Given this list of marker genes CLCN2, CLCN3, CLCNKA, ANO6, CLCN4, TMC4 (NCBI Gene Id 147798), CLCNKB (chloride voltage-gated channel Kb), CLCN1, CLCN6, ANO1, CLCN5, here is a description of the gene set: Human Gene Set: GOMF_VOLTAGE_GATED_CHLORIDE_CHANNEL_ACTIVITY studied in species Homo sapiens Enables the transmembrane transfer of a chloride ion by a voltage-gated channel. A voltage-gated channel is a channel whose open state is dependent on the voltage across the membrane in which it is embedded.